Given this list of marker genes CCDC97, CD209, LINC02604, RHOBTB2, ANKEF1, OST4, MFSD11 (NCBI Gene Id 79157), TWNK, FAF2, NUP210L, NAA60, DCTN5, PSMG3, DSTYK, CCS, MRFAP1L1, MTCH1, ZNF688, STRADA, XPA, PNRC2, THAP9, SLC6A16, CEACAM21 (CEA cell adhesion molecule 21), OCEL1 (occludin/ELL domain containing 1), SETD7, SNHG33, RNF139, PCYOX1, SIDT2, TUBGCP3, HLA-DRB4 (NCBI Gene Id 3126), NAXD, CCL2, MOB1A, HHEX, PTPN18, IFITM1, ABCB6, SNRNP35, KLRF1, RCAN1, ELAC1, EEF2K, ENTPD6, ELP1, CEP20, NSL1, LCMT2, JADE2, GRHPR, SIX6, FBXO5, UNC13B (NCBI Gene Id 10497), HDAC4, HNRNPD, VPS28, TSC1, ZNF438, SS18L2, NBR2, TOR1AIP1, PIP5K1B, RPP25L, RFC4, G6PC3, RHPN1-AS1, ZNF532, RAMAC, PPP4R3C, CNP, SLC43A1, ADRB2, TMEM109, RTP4, PATZ1, ZKSCAN4, ZC3H7B, ARV1, BRD3, ANKMY2, CPA3, ANAPC4 (NCBI Gene Id 29945), FBXL4, SIDT1, TMEM184C, FBXL19, EEF2KMT, POC5, ASMTL-AS1, RECK, HCLS1, RYR2, EFCAB14, FRAT2 (FRAT regulator of WNT signaling pathway 2), FCHSD1, WDR53 (NCBI Gene Id 84977), ALG2, VPS16, GIMAP7, GRAP, CBY1, RGSL1, UBAC1, LINC00957, TGS1, GPR65, STX16, ANKRD36B, HSPA1A, LBH, MED22, CDR2, PEX11B, LAMB2, SLC27A2, EI24, MIR22HG, CLEC4GP1, AIFM1, TTC13, MEPCE, NACC2, PRMT7, AASDH (NCBI Gene Id 132949), UCP2, YIPF1, PMS1, C14orf119, NDN, MINDY1, BOLA1, HSD17B12, TBCD, DMAP1, ARFGAP2, B3GALT4, CENPBD1P, GYPC, SNHG1, SLC24A4 (NCBI Gene Id 56796), F9, RBBP9, PPIL1, COLCA1, DEF8, ZC3H8, RASEF, FAM13B, HSPB8, TRIM32, C2orf42, TMEM129, PIGV, DGLUCY, CHTF8, ZNF581, CEP63, PSMC5 (NCBI Gene Id 5705), TSHB, NBAS, LINC01116, MOCS2, PIH1D1, TCTN3, AGPAT5, CEP57, BMP6, MTMR9, COL23A1, SH3PXD2A, RFLNB, GOLGA8H, LINC00899, WDR24, KIAA0232, CELF6, SMYD2, ENPP6, ZNF880, RHNO1, TRAPPC4, ZMYM1, CDC42SE1, IL23R, AP5S1, YAE1, NKAPD1, SRSF1, DNAJC5B, TMEM65, POLR1B, PHF14, TMBIM4, PEX6, ZNF691, TRIM25, PTGS1, here is a description of the gene set: from publication Zietara N, Łyszkiewicz M, Gekara N, Puchałka J, Dos Santos VA, Hunt CR, Pandita TK, Lienenklaus S, Weiss S (PMID 19581626) studied in species Homo sapiens Genes down-regulated in CD8A- splenic dendritic cells: wildtype versus IFNAR1 knockout mice. Type I Interferons encompasses a large family of closely related cytokines comprising of at least 13 IFN-α isotypes and single IFN-β. Both IFN-α and IFN-β exert their activity through a common receptor IFNAR. Type I Interferons have broad regulatory effects and various subtypes of dendritic cells are influenced by this cytokines. In our study we asked question whether the low, constitutive levels of type I Interferons produced under steady state conditions are important for proper function of splenic conventional dendritic cells. Human Gene Set: GSE12392_WT_VS_IFNAR_KO_CD8A_NEG_SPLEEN_DC_DN